Given this list of marker genes Nr4a1, Nr4a3, Crhr1, Crhr2, Nr4a2, here is a description of the gene set: Any process that results in a change in state or activity of a cell or an organism (in terms of movement, secretion, enzyme production, gene expression, etc.) as a result of a corticotropin-releasing hormone stimulus. Corticotropin-releasing hormone is a peptide hormone involved in the stress response. Mouse Gene Set: GOBP_RESPONSE_TO_CORTICOTROPIN_RELEASING_HORMONE studied in species Mus musculus